The following is a description of a gene set: Mouse Gene Set: REACTOME_SODIUM_CALCIUM_EXCHANGERS studied in species Mus musculus Sodium/Calcium exchangers, and this is the list of marker genes: Calm2, Sri, Slc8b1, Slc24a4, Calm3, Slc8a1, Slc24a3 (NCBI Gene Id 94249), Slc8a3, Calm1 (calmodulin 1), Slc8a2, Slc24a1, Slc24a2, Slc24a5